The following is a description of a gene set: A process, occurring in skeletal muscle, that is characterized by a decrease in protein content, fiber diameter, force production and fatigue resistance in response to different conditions such as starvation, aging and disuse. Human Gene Set: GOBP_SKELETAL_MUSCLE_ATROPHY species: Homo sapiens, and this is the list of marker genes: ACTN3, MSTN, ASB2, CFLAR, TRIM63